The following is a description of a gene set: Mouse Gene Set: GOMF_DIPEPTIDE_TRANSMEMBRANE_TRANSPORTER_ACTIVITY Enables the transfer of a dipeptide from one side of a membrane to the other. A dipeptide is a combination of two amino acids linked together by a peptide (-CO-NH-) bond. studied in species Mus musculus, and this is the list of marker genes: Slc15a2, Slc15a3, Slc15a1, Slc15a4, Mfsd1